The following is a description of a gene set: Human Gene Set: GSE3720_VD1_VS_VD2_GAMMADELTA_TCELL_UP species: Homo sapiens from publication Kress E, Hedges JF, Jutila MA (PMID 16423401) Genes up-regulated in gamma delta T cells: Vd1 versus Vd2. The two major human gd T cell subsets, Vd1 and Vd2, display differences in tissue tropism and agonist responses, but we have little insight into global differences that may exist at the gene expression level. This is due to the small numbers of these cells that can be obtained from healthy donors, which limit comprehensive, comparative gene expression analyses. We established a culture method that expands Vd1 and Vd2 cells from the same PBL preparation to levels sufficient for sorting and microarray analysis. Although the subsets were expanded identically (anti-TCR mAb, plus IL-15), 392 and genes were identified, which were differentially expressed in the two subsets, from two donors, respectively. Approximately genes changed in both subsets following PMA/ionomycin treatment; about 50% of these genes were subset-specific. Both subsets responded to a crude LPS preparation, but only 6% of the responsive genes were the same. The differentially expressed genes were consistent with Vd2 cells being more inflammatory and Vd1 cells having more of a regulatory phenotype. Both subsets expressed transcripts encoding an array of innate and NK cell receptors, supporting the relationship of gd T cells to the innate immune system. Our results show that circulating Vd1 and Vd2 subsets in humans have considerable, inherent differences in gene expression following treatment with non-TCR agonists, supporting unique functional roles for these cells in vivo., and this is the list of marker genes: GPR143, RBM14, FAM53C, RANBP1, SERPIND1, MECOM (NCBI Gene Id 4197), RAB30, CCDC89, MMP12, COL9A3, IL36G, SYTL4, DDO, TSR2, TAPBPL, DUS1L, BUB3, NDC1, FASN, MAPK4, PXMP2, H3-5, LDB2, AGFG1, TMEM14C, CTPS1, TSPY1, COPS8, CEMIP2, TRMT12, SPEF1, MCM3, PPA1, ZFPM2, C1QTNF7, SPDL1, TRIP13, NME1, GPR161, TSPAN4, HSPA5, TLR7, CLCNKB, BAZ1B, SEC11A, CCKBR, GEMIN6, KCNA4, TIGAR, TMEM158, OTUD6B, SLC25A17, CBX3, ALAS1, NSUN2, ELP1, COPS7A, GABRR2, YWHAB, PRODH, DHX37, PPP3R2, EIF3B, ERCC6L, PPHLN1, DCAF13, ALG8, MCM5, FAM111A, GLP1R, STRAP, CDX4, SNAPC5, CADPS2, IFI44, CALHM6, ZBP1, BLVRA, MTM1 (myotubularin 1), LSM3, CDK7, HS6ST3, POLR2F, CLDN19, UNCX, RNF115, MRPL11, HSPD1, PRICKLE2, DRD2, NMBR, EME1, SDK2, LCAT, DYNLRB2, LGR5, TMEM35A, KLK11, MC2R, RFC5, FMR1, NOB1, KLK10, POU3F4, TCF20, BANF1, KPLCE, EPS8L2, PPP1R8, ADRA2C, DHX29, CLP1, ERF, NTS, TIPIN, ELF5, SLC35F1, UTP6, POLE, COMTD1, RIOX1 (ribosomal oxygenase 1), PMS1, CYB561D2, ATP5PF, NUCKS1, LYAR, WARS1, DNAJC9, TIMM13, PRDX3, MAK16, EIF5A, CXCL10, OTUD4, SNF8, SEMA6C, KCNE2, MCM10 (minichromosome maintenance 10 replication initiation factor), MRPL42, NFAM1, SLC43A1, YTHDC1, MRPL21, TRMT10A, PSMB11, FEN1, ZPBP2, MRPS18A, HLCS, PPP1R14B, MCOLN2, RTP4, TRIM37, CTCF, EIF5, SPINK2, TPST1, ST6GALNAC5, PANX1, LRPPRC, PARP14, TEAD4, CCL1, EPB41L4A, TMTC1, WNT1, TEX11, NDN, SH3BP2, DRP2, CGAS, POP1 (NCBI Gene Id 23044), SFPQ, RPA1, PRG3, PHRF1, TMA16, NDUFAF2, NLRP9, UGT2B4, RETREG3, DHFR, EXO1, COA3, DGKI, TBX1, MRPS18B, MYCN, STT3B, FITM2, PSMD12, LRR1 (leucine rich repeat protein 1), SRFBP1 (serum response factor binding protein 1), OOEP, CCL4, ENTPD7, CIDEB, RNF213